The following is a description of a gene set: The presence of convoluted folds and furrows formed from thickened skin of the scalp, resembling cerebriform pattern. The scalp has convoluted and elevated folds, 1 to 2 cm in thickness. The convolutions generally cannot be flattened by traction. Cutis gyrata of scalp species: Homo sapiens Human Gene Set: HP_CUTIS_GYRATA_OF_SCALP, and this is the list of marker genes: AIP, HPGD, GPR101, SLCO2A1, FGFR2, NDE1